Given this list of marker genes SRY, NR0B1, NR5A1, DHX37, DMRT1, DHH, MAP3K1, TSPYL1, GATA4, SOX9, ARX, CBX2, WT1, here is a description of the gene set: Testicular dysgenesis Human Gene Set: HP_TESTICULAR_DYSGENESIS studied in species Homo sapiens